The following is a description of a gene set: from publication Kaji T, Ishige A, Hikida M, Taka J, Hijikata A, Kubo M, Nagashima T, Takahashi Y, Kurosaki T, Okada M, Ohara O, Rajewsky K, Takemori T (PMID 23027924) studied in species Homo sapiens Genes down-regulated in day 7 germinal center B cells versus day 40 germinal center B cells. To obtain insight into the genetic basis of the increase of functional activity of memory B cells over time, we compared the gene expression profiles of day 7 and day 40 NP-specific/IgG1 memory B cells, GC B cells and plasma cells in immunized WT mice and naïve B cells, before and after activation in vitro. Human Gene Set: GSE11961_GERMINAL_CENTER_BCELL_DAY7_VS_GERMINAL_CENTER_BCELL_DAY40_DN, and this is the list of marker genes: SF3B2, MRPS18B, LTB, PLD4, PFN2, ZNF131 (NCBI Gene Id 7690), TRIM34, GSDMA, SLC29A3, PSCA, SIT1, KRBA1, CXCR4, EPS8L1, ERMARD, SCAF11, ARHGEF12 (Rho guanine nucleotide exchange factor 12), GPM6A, TEC, NEU1, MCCC1, ATF7IP, GRIK3, CETN1, LYNX1, PTK2B, GAMT (guanidinoacetate N-methyltransferase), GNAT2, TMEM17, TAOK3, STK4, BTBD1, CCR6, ST14, STX16, GPR152, IGLON5, BCL9L, KCNG1, USF1, ADAMTS6, MAST4, FHIP1A, FAM3B, CLEC4M, POLR1A, ZFYVE19, MARCKSL1, ERCC5, NPHS1, KHNYN, MXD4, DYRK1A (dual specificity tyrosine phosphorylation regulated kinase 1A), SEC14L5, SLC49A4, TTC23, CRYZ, HLA-G, ZNF318, IL4R, HEG1, CRLF3 (cytokine receptor like factor 3), DPP7, DDX18, CHD2, CSMD1, CIART, INSR, RTF2, PRR12, INPP5K, H2AC25, BBS10, CLCN6, ATP8A1 (NCBI Gene Id 10396), C1QTNF9, UVRAG, ANKRD55, PECR, PIK3R3, TRIB2, SKOR1, ADM, NAT10, PMEPA1, EPS8, PELI1, SNX8, CLDN1, CIRBP, STXBP4 (NCBI Gene Id 337994), VPS51, HLCS, CAMKK1, LIAT1 (NCBI Gene Id 400566), WDFY4, BAZ2B, APOE (NCBI Gene Id 99), AIF1, RPRD1A, MLH3, IRF1, BCO2, TMPRSS13, F8, CLDN10, BCL6 (NCBI Gene Id 604), HSFY2, KIAA1958, IFT172, GPATCH4, RIC8A, SLAMF6, PLCD3, PGAM5, DNAJC7, RDH5, AFF3, NTHL1, ACTN1, SUN2, PROKR2, TCF25, RAB39A, CNOT2, IFT25, UBC, NLRC5, PRKAB2, CD86, PPM1L, MEF2D, MGST1, IFT81, SLC37A2, MIDEAS, BFSP2, OVGP1, BPHL, APOBEC1, ZNF319, DENND1A, VWCE, MRPL39, PCBP2, IPO4, NUAK2, RIGI, SAA2 (NCBI Gene Id 6289), MYO1C, ATP6V0B (ATPase H+ transporting V0 subunit b), TPRG1L, USP7, ALOX5AP, MYCBP2, CHD9, PRG4, PPP4R3B, PHLPP1, TMED6, CEP164, CMTM6, TMOD4 (tropomodulin 4, NCBI Gene Id 29765), RBM19, ZMYM3, LYN, DDX17, SPRY1, LTO1, CMTR1, CC2D2B, KCNMB1, IRF2, UBA7, ERP27, HMGN3, PTPRJ, HAVCR1, TSTD1, C15orf39, EVI5, TMEM192, PHKA1, ANKRD37, TRPM5, CCT6B, ANKRD46, ADAT1, EARS2, DMAC2, ASH1L, SLC66A1, IMMP2L, OSGEP, CLK2, PGPEP1L, RESP18 (NCBI Gene Id 389075), MATCAP1, PLEKHA2